Given this list of marker genes MBNL1, HS3ST3B1, CYP26B1, MTOR, ADCY1, CTDSPL, EPDR1, AGO2, TRIB2, ICMT, HOXA1, HS3ST2, SLC44A1 (solute carrier family 44 member 1), AP1AR, FGFR3, FZD8, KBTBD8, RAVER2, BAZ2A, SMARCA5, INSM1, ZZEF1, MTMR3, here is a description of the gene set: Genes having at least one occurence of the motif TACGGGT in their 3' untranslated region. The motif represents putative target (that is, seed match) of human mature miRNAs hsa-miR-99a, hsa-miR-100 and hsa-miR-99b (v7.1 miRBase). studied in species Homo sapiens Human Gene Set: TACGGGT_MIR99A_MIR100_MIR99B